Given this list of marker genes DYRK1A, NFIX, MDGA1, FKBP8, ZFR2, SLC17A7, PIP5K1C, PABPC1L2A, HOXC10, NRARP, SCRT1, FAAP20, ABO, C1QTNF6, UBXN6, EEF1A2, SIRT6, TGFB1 (NCBI Gene Id 7040), MIA2, ACSL3, DUOXA2, PABPC1L2B, AP5Z1, TNFRSF8, DPP9, ESPN, SLC29A3, here is a description of the gene set: studied in species Homo sapiens Human Gene Set: MIR6787_5P from publication Chen Y, Wang X (PMID 31504780) Genes predicted to be targets of miRBase v22 microRNA hsa-miR-6787-5p in miRDB v6.0 with MirTarget v4 prediction scores > 80 (high confidence targets).